The following is a description of a gene set: species: Homo sapiens Human Gene Set: HP_ABNORMALITY_OF_THE_GINGIVA Abnormality of the gingiva Any abnormality of the gingiva (also known as gums)., and this is the list of marker genes: PRF1, RMRP, GALE, MIA3, HPS1, WRAP53, DKC1, DDR2, KCNJ6, NCF4, IRF2BP2, HIVEP2, PERP, FIG4, SETBP1, TBL2, FGA, ELN, PIGN, GPC4, CTSC, KCNMA1, ATG7, B4GALT7, CDKN1A, FAT4, TBCK, KIF23, GCSH, F13B, CCBE1, NPM1, TRIM8, WIPF1, NUMA1, FGB, CXCR4, IDUA, TWIST2, LIMK1, HYLS1, GPC3, NCF1, FBXO28, RTEL1, ZBTB16, PARN, AP3B1, MYSM1, STX1A, GTF2IRD1 (GTF2I repeat domain containing 1), IL18BP, C1S, CLTRN, AFF3, GORAB, RIN2, SAMD9, ABCC9, RACGAP1, JAK2 (Janus kinase 2), ECM1, PIGS, TBC1D24, LBR, ADAMTS2, FERMT1, MBTPS2, METTL27, NABP1, CDKN2C, EXTL3, ANKH, SLC35C1, GJB6, ZNHIT3, DNAJC30, INSR, LMAN1, KCNH1, MCFD2, MGAT2, BCOR, TCIRG1, SOS1, SCARB2, SLC29A3, FGF3, DNM1, CYBA, NXN, GTF2I, GP1BA, NGF, KCNN3, WDR26, ELANE, CLPB, KCNK4, WAS, STAT3, CD96, ASXL3, NTRK1, GBA1, NCF2, ALMS1, IDS, F10, USP9X, SRP19, KIF7, VAC14, TERT, SH3PXD2B, GP1BB, GFI1, CNTNAP1, OSTM1, RARA, BAZ1B, EIF4H, PML, IFNG, MEN1, TINF2, F2, VPS37D, OCRL, ELOVL4, NOTCH2, KRT6A, ROR2, ABCA5, WNT5A, DHCR7 (7-dehydrocholesterol reductase), RALGAPA1 (NCBI Gene Id 387984), TBL1XR1, TMCO1, F8, DVL3, CD40LG, CDKN2B, CDKN1B, GNAQ, ANTXR2, SMAD4, HYMAI, SLC6A19, PIGA, FKBP6, F13A1, MYD88, FCGR2C, CAT, FIP1L1, DHCR24, USB1, AGA, SC5D, NOTCH3, TMEM270, IER3IP1, BUD23, GUSB, MMP2, SLC37A4, NFIX, EMC1, LYST, AIMP2, ITGB3, BLOC1S5, MAP1B, PRMT7, C1R, PRKAR1A, PDGFRB, TCTN3, PLG, TRPV3, PLCG1, ELMO2, LMNB1, ZEB2, NHP2, COL3A1, F7, IRF9, CLIP2, ITGA2B, FAM20A, CYBB, TSC1, NOP10, FGG, SEC61A1, GLB1, MAN2B1, BLOC1S3, RFC2, CTC1, MMP14, SERPINF2, TYMS, DVL1, REST, PLEKHM1, GP9, ITGB2, STAT5B, GJB2, HPS3, DSP, NEU1, VPS13B, FGFR2, ADAMTS3, NKX6-2 (NK6 homeobox 2), PLAGL1, TSC2, FAM20C, GTF2IRD2, FYB1, TBC1D2B, BGN, GNPTAB, FZD2, ATP6V1B2, SLC17A5, F5, SBDS, CYBC1, TERC, AEBP1, SATB2